The following is a description of a gene set: Nucleotide catabolism Human Gene Set: REACTOME_NUCLEOTIDE_CATABOLISM species: Homo sapiens, and this is the list of marker genes: GDA, ENTPD4, NUDT16, ENTPD5, ADPRM, UPP2, DPYD, PNP, NUDT5, TYMP, UPB1, NT5E, NUDT1, NUDT18, NUDT9, UPP1, NT5C2, NT5M, ENTPD2, DNPH1, ENTPD8, NT5C1A, ITPA, ENTPD6, NT5C (NCBI Gene Id 7370), DPYS, NT5C3A, ENTPD3, AGXT2, NUDT15, SAMHD1, ENTPD7, XDH, NT5C1B, ENTPD1